Given this list of marker genes Nfe2l1, Terf1, D1Pas1, Piwil1, Topaz1, Mlh1, Ttk, Ube2b, Haspin, Fance, Cdc20, Piwil2, Mei1, Spo11, Xrcc5, here is a description of the gene set: Mouse Gene Set: GOBP_M_PHASE species: Mus musculus A cell cycle phase during which nuclear division occurs, and which is comprises the phases: prophase, metaphase, anaphase and telophase.